Given this list of marker genes Lrpap1, Lrp1, Rab11a, Cltc, Rab5a, Rab11b, Picalm, here is a description of the gene set: Mouse Gene Set: GOBP_AMYLOID_BETA_CLEARANCE_BY_TRANSCYTOSIS studied in species Mus musculus The process in which amyloid-beta is removed from extracellular brain regions by cell surface receptor-mediated endocytosis, followed by transcytosis across the blood-brain barrier.